Given this list of marker genes PELI1, RPS27A, TNFRSF10B, RIPK1, FAS, SDCBP, TNFRSF10A, FADD, UBC, UBA52, FLOT2, CASP8, MLKL, CFLAR (NCBI Gene Id 8837), RIPK3, ITCH, STUB1, FLOT1, CDC37, PRKN, OGT, BIRC3, FASLG, TRADD, BIRC2, UBB, XIAP, PDCD6IP, HSP90AA1, UBE2L3, TNFSF10, TRAF2, here is a description of the gene set: species: Homo sapiens A regulated balance between cell survival and cell death is essential for normal development and homeostasis of multicellular organisms. Defects in control of this balance may contribute to autoimmune disease, neurodegeneration, ischemia/reperfusion injury, non alcoholic steatohepatitis (NASH) and cancer. Reactome Pathway: Regulation of necroptotic cell death part of: RIPK1-mediated regulated necrosis